The following is a description of a gene set: Mouse Gene Set: GOMF_RNA_ENDONUCLEASE_ACTIVITY_PRODUCING_5_PHOSPHOMONOESTERS studied in species Mus musculus Catalysis of the hydrolysis of ester linkages within ribonucleic acids by creating internal breaks to yield 5'-phosphomonoesters., and this is the list of marker genes: Ago2, Elac1, Rnaseh1, Prorp, Drosha, Ago3, Pop4, Nudt16l1, Rpp40, Rpp21, Cwf19l1, Rpp30 (ribonuclease P/MRP 30 subunit), Rpp25, Rpp38, Rnaseh2a, Pop1, Nudt12 (nudix hydrolase 12), Nudt16, Endov, Pop5, Pld6, Dicer1 (NCBI Gene Id 68462), Nudt16l2, Mrpl44, Nynrin, Elac2, Rpp14, Dbr1, Fen1, Pop7